Given this list of marker genes FCER1G, MIR302E (microRNA 302e), SELENOS, HLA-E, FCGR1A, C3, PLA2G2D, FCGR2B, PARK7, SPN (NCBI Gene Id 6693), IL20RB, NPY5R, ZP3, FUT7, CCR7, NPY, BTK, here is a description of the gene set: species: Homo sapiens Human Gene Set: GOBP_REGULATION_OF_ACUTE_INFLAMMATORY_RESPONSE_TO_ANTIGENIC_STIMULUS Any process that modulates the frequency, rate, or extent of an acute inflammatory response to an antigenic stimulus.